The following is a description of a gene set: species: Homo sapiens Human Gene Set: WP_BARDETBIEDL_SYNDROME Bardet-Biedl syndrome, and this is the list of marker genes: CFAP418, RAB23, NEK1, BBS4, DCDC2, TMEM67, CILK1, BBS1, BBS7, IFT122, CLUAP1, PCARE, IFT80, SMO, CNGB1, SUFU, CEP290, BBS2, CEP41, LCA5, BBS10, CNGA1, ARL13B, SCLT1, MKS1, CEP104 (centrosomal protein 104), PKD2, CFAP410, INPP5E, EVC (NCBI Gene Id 7886), WDPCP, DYNC2LI1, PDE6D, TTC21B, NEK8, GLI2, PKD1, OCRL, IFT74, EVC2, WDR19, IFT52, IFT140, MKKS, TMEM107, DYNC2H1, DYNLT2B, PTCH1, TRIM32, ARL6, CEP164, TMEM216, GPR161 (G protein-coupled receptor 161), EFHC1, LZTFL1, IFT27 (intraflagellar transport 27), IFT57, INVS, IQCB1, ZIC2, USP9X, BBS9, WDR35, DYNC2I2, FUZ, GLI3, SCAPER, BMAL1, IFT43, BBIP1, FLCN, EFHC2 (EF-hand domain containing 2), TRAF3IP1, ARL3, PKHD1, PKD1L1, SDCCAG8, CRX, DYNC2I1, IFT172, NPHP3, MAK, BBS12, TTC8, IFT81, KIF7, RP2, BBS5